The following is a description of a gene set: from publication Jeffrey KL, Brummer T, Rolph MS, Liu SM, Callejas NA, Grumont RJ, Gillieron C, Mackay F, Grey S, Camps M, Rommel C, Gerondakis SD, Mackay CR (PMID 16474395) Human Gene Set: GSE3982_MAC_VS_EFF_MEMORY_CD4_TCELL_UP Genes up-regulated in comparison of macrophages versus effector memory CD4 T cells. studied in species Homo sapiens In the present study we used Affymetrix oligonucleotide microarrays to produce gene transcription profiles for the major leukocyte types in humans. This comprehensive dataset enabled us to not only establish which genes were expressed in each leukocyte type, but also which genes were expressed in each subset after activation. The used of a comprehensive dataset of gene profiles from all the major human leukocyte subsets enabled a novel and powerful means for identification of genes associated with single leukocyte subsets, or different immune paradigms., and this is the list of marker genes: GTF2IRD1, POLR2K, P2RY13, AMOTL2, ACSF2, PPME1, PLA2G4A (NCBI Gene Id 5321), PNMA1, TVP23B, SDCBP, CLCN7, DNAAF2, SERPINA2, ATP5PF (ATP synthase peripheral stalk subunit F6), IL13RA1, PLAU, CLMN (NCBI Gene Id 79789), AGGF1, KMO, KCNMA1, TECR, RAB23, CLIP4, CD1D, HSPB1, TIMM8B, PDXK, SLC7A8 (solute carrier family 7 member 8), UBE2E1, ARMCX3, ENPP2, UQCRC2, STXBP1, RTN3, PPARD, BCL2L1, SLC2A5, MRPS33, SEC24D, MTCH2, DBI (NCBI Gene Id 1622), MGST2, VCP, H1-0, CCL22, NRGN, MRPL40, ASPHD1, METTL13, CLIC2, TMEM14B, FZD5, SOCS5, ADAM15, TIMM17A, S100A8, TSPAN4, LRP3, PAQR5, NFE2, NDUFA6, PDE8A, ANXA5, AHCYL1, C3, RUBCNL, GINS1, PPP2R3A, DOCK3, ETHE1, GSPT1, PISD, ALCAM, FST, PIP5K1C, COL8A2, TPM3, SDHB (succinate dehydrogenase complex iron sulfur subunit B), PIK3CB, TRIO, LILRA2, FRMD4A, BACH1, TMEM140, PROC, CENPU, PSEN1, GPER1, BRCA1, PLXNC1, ADGRE3, STX7, HEBP1, SCPEP1, GNPDA1, EMC1, KIF11, IMPACT (impact RWD domain protein), ZNF267, ANXA2P1, SAT1, SEL1L, IGFBP7, ELOC, ZBTB10, ME1, CTSH, ATP6AP1, BAZ2B, GALNS, ANPEP, PLS1, CSF1, MRPL15, NDUFS1, ABCB9 (NCBI Gene Id 23457), MLST8, CERS2, SLC1A4, PICALM (phosphatidylinositol binding clathrin assembly protein), RNPEP, ADAP2, CCDC6, POLD1, NDUFC1 (NADH:ubiquinone oxidoreductase subunit C1), ATP5MC1, SLC6A6, CALML4, PLA2G4C, GATM, PSMC4, GNAI3, CLIP2, CNIH3, FCHSD2 (NCBI Gene Id 9873), C8orf33, ST13, CKS2, NKAPD1, NDUFV2, PHACTR1, LYSET, EVI5 (ecotropic viral integration site 5), TM6SF1, PRDX3, REPS2, PBX3, SULT1C2, EPB41L2, ZNF804A, BLOC1S1, MTMR6, SLC12A8, DPYSL2, MSRB2, GAPDHS, MGST3 (microsomal glutathione S-transferase 3), RAB32, PCTP, LDLRAD4, SEC61A1, SERINC3, KDELR2, CLEC4A, E2F6, QPRT, BTBD7, NDUFA8, PPIF, NTAN1, ENY2, CLN8, ITGAX, TRPV2, APPL1, SNX24, UTP11, OPA1, MCTS1, CCL8, CTNS, ACO1, MFAP3, FUT4, QPCT, COX5B, ADIPOR1, ANKRD13C-DT, ARMT1, TEX2, CD83, UBE2D1, ABCC3, SLC25A13, FAM162A, FUCA1, ADGRA3, ARMCX1, TXNRD1, SHB